The following is a description of a gene set: Reactome Pathway: Transport to the Golgi and subsequent modification species: Homo sapiens At least two mechanisms of transport of proteins from the ER to the Golgi have been described. One is a general flow requiring no export signals. The other is mediated by LMAN1/MCFD2, mannose-binding lectins that recognize a glycan signal (Zhang B et al, 2003). part of: Asparagine N-linked glycosylation, and this is the list of marker genes: SEC24A, MGAT2, GOLGA2, TUBAL3, MANEA, COL7A1, FUT3, SEC16A, BET1, FUCA1, B4GALT3, COG3, TUBA1C, LHB (NCBI Gene Id 3972), TFG, ACTR1A, COPE, MIA2, MAN1A1, NAPA, MAN2A2, GORASP1, DCTN3, TUBA3E, DCTN5, COPG2, DYNLL2, SPTBN5, ANK3, NAPG, COG2, CGA, SEC23IP, RAB1A, SPTAN1, TUBA3D, SCFD1, COPA, ARF1, CTSZ, CHST10, B4GALT5, TMED7, TMED3, CD59, AREG, MIA3, TUBB6, TUBB3, NAPB, MGAT5, TUBB4A, TUBB1, SPTBN4, PPP6R1, CAPZA2, MCFD2, KDELR2, B4GALT1, TRAPPC6B, MGAT1, PPP6R3, DYNC1I1, FUT8, TRAPPC3, MGAT3, TRAPPC6A, GOLGB1, TRAPPC2L, COPG1, COPB2, SPTB, TBC1D20, USO1, F8, CD55, DYNC1LI1, CAPZA3, BET1L, ARFGAP3, DYNC1H1, SEC23A, ARFGAP2, TUBA1A, SEC24C (NCBI Gene Id 9632), TRAPPC4, COG4, STX17, SEC22C, SPTBN1, B4GALT4, ANKRD28, TUBA4A, TGFA, TMED9, TUBA1B, MAN2A1, COG5, TUBB8B, MAN1C1, ARCN1, SAR1B, TUBB4B, TRAPPC2, MGAT4C, GOSR2, TRAPPC9, B4GALT6 (NCBI Gene Id 9331), YKT6, ARF3, CHST8, MGAT4A, COG8, TUBA3C, PREB, SEC16B, SEC31B, SEC22A, ST3GAL4, ST8SIA2, CNIH2, ARF5, COPZ2, ANK1, DCTN2, SPTBN2, TUBB8, TUBA4B, DCTN1, CAPZA1, TMED10, PPP6C, DYNLL1, ST6GAL1, TMED2, LMAN1, COG7, TRAPPC5, TMEM115, DYNC1LI2, CTSC, RAB1B, SPTA1, CAPZB, ST8SIA3, INS, GRIA1, LMAN2 (NCBI Gene Id 10960), DCTN4, MAN1A2, SEC24B, SEC13, ACTR10, ST8SIA6, SEC31A, LMAN2L, GOSR1, CSNK1D, TRAPPC1, ANK2, CNIH1 (cornichon family member 1), ARFGAP1, COG1, COG6, KDELR3, LMAN1L, SEC22B, ARF4, GBF1, TUBB2B, TUBA8, KDELR1, CNIH3, FOLR1, SEC24D, TRAPPC10, TUBB2A, B4GALT2, DYNC1I2, COPZ1, MGAT4B, COPB1 (COPI coat complex subunit beta 1), SERPINA1, STX5, NSF (NCBI Gene Id 4905), DCTN6, F5